Given this list of marker genes ESS2, DGCR6, DGCR2, TBX1 (T-box transcription factor 1), DGCR8 (NCBI Gene Id 66034), STRA6, CRELD1, here is a description of the gene set: Human Gene Set: HP_RIGHT_AORTIC_ARCH_WITH_MIRROR_IMAGE_BRANCHING studied in species Homo sapiens Right aortic arch with mirror image branching The aortic arch crosses the right mainstem bronchus and not the left mainstem bronchus, but does not result in the creation of a vascular ring. The first branch is the left brachiocephalic artery which divides into the left carotid artery and left subclavian artery, the second branch is the right carotid artery, the third branch is the right subclavian artery.